The following is a description of a gene set: from publication Chen Y, Wang X (PMID 31504780) Mouse Gene Set: MIR_20A_5P studied in species Mus musculus Genes predicted to be targets of miRBase v22 microRNA mmu_miR_20a_5p in miRDB v6.0 with MirTarget v4 prediction scores > 80 (high confidence targets)., and this is the list of marker genes: Derl2, Phip, Frs2, Sema4b, Klf11, Cnot6l, Ppp1r3e, Pcdha6 (protocadherin alpha 6), Rps6ka1, Rp2, Osm, Tmem64, Kmt2a, Bicd2, Sobp, Tppp, Wasf1, Pcdha3, Npas2 (NCBI Gene Id 18143), Col19a1, Foxj2, Adam9, Midn, Tasor, Pkd2, Retreg3, Sertad2, C2cd2, Rab8b, Ccdc71l, B3galt2, Tspan9, Septin2, Rhoc, Dock4, Mmp24, Elk3, Lypd6, Map3k8, Map7, Myt1l, Limk1, Nek9, Csnk1g1, Panx2, Fbxo31, Arhgap12, Rab5b, Rab30, Rgmb, Gpc6, Rab3gap1, Rassf2, Pdcd1lg2, Topors, Rapgefl1, Ankrd33b, Nckap5, Kdm2a, Ppp1r3b, Pcdha5, Crybg3, Irf2bp2, Tanc2, Col4a4, Cbln4, Ythdf3, Irf9, Rb1, Plekha7, Trappc14, Pcdhac1, Tle4, Itgb8, Plxdc2, Rnf128, Pcdha8, Ntng1 (NCBI Gene Id 99752), Dnal1, Celsr2 (cadherin, EGF LAG seven-pass G-type receptor 2), Ano3, Fat4, Fyco1, Hs3st5, Il25, Reps2, Mosmo, Map6d1, Epha4, Zbtb18, Pak5, Marchf8, Slc17a8, Gramd1a, Ankrd17, Susd6, Acer2, Cald1, Snx8, Tph1, Rundc1, Zfpm2, Klhl28, Nr2c2, Prrg1, Aak1, Unk, Ube2q2, Egln3, Snx16, Aktip, Ss18l1, Slc24a2, Btbd10, P2rx4, Gbf1, Rcan3, Map3k14, Rgs17, Rap2c, Kif23, Map3k12, Slc25a36, Creb5, Rnf6, Klf9, Slc2a4, Osr1 (odd-skipped related transcription factor 1), Usp24, Tfb2m, Ppp1r21, Psd, Hbp1, Agfg2, Tsg101, Tmcc3, Enpp5, Slc49a4, Igsf10, Itpripl2, Spopl, Foxj3, Rsbn1, Usp3, Fzd3, Oxr1, Usp46, Cnot7, Arhgef10, Sema7a, Abca1, M6pr, Zdhhc1, Camta1, Eif4a2, Fam13c, Slc40a1, Gosr1, Coro2b, Lrp8, Znfx1, Stk38, Kpna2, Trip11, Pxk, Tmem127, Fam117b, Jpt1, Ptpn4, Tgfbr2, Slc16a9, Atxn7l1, Rab22a, Fibin, 1600012H06Rik, Smim5, Skor1 (SKI family transcriptional corepressor 1), Zfyve26, Sybu, Npat, Pcdha2, Nrip3, Arhgap26, Pafah1b1, Ints14, Trip10 (NCBI Gene Id 106628), Cdc37l1 (NCBI Gene Id 67072), Ankrd52, Arhgap1, Cfl2, Map3k2, Kif3b, Nabp1, Pcdha10, Luzp1, Mylip, Fcho2, Fastk, Tiam1, Ago1, Ddhd2, Fjx1, Stk11, Zbtb41, Dcaf8, Retreg2, Smyd1, Ddhd1 (DDHD domain containing 1), Kat2b, Zfp512b, Jazf1, Reep3, Nagk, Arhgef11, Creb1, Kif5a, 2510009E07Rik, Flt1, Cmpk1, Tnks2, U2surp, Hook3, Mknk2, Rab11fip5, Sqstm1, Gpr137b, Polr3g, Ncoa3, Zdhhc8, Ankrd13c, Atg16l1, Sumf1, Myf5, Brms1l, S1pr1, Tnfrsf21, Golga1, Neurog2, Armc8, Ptchd4, Cdca7, Wdr37, Smoc2, Ankrd9, Timp2, Mier1, Pbx3, Zfp800, Lrch1, Slc18a2, Pcdha9, Rgma, Naa30, Bnip2, Bahd1, Tbc1d9, Sfmbt1, Dpysl2, Laptm4a (lysosomal-associated protein transmembrane 4A), Ulk1, Pde3b, Slc6a9, Rps6ka5, Arhgef18, Pkd1, Rs1, Camk2n2, Dsg4, Atl3, Suco, Zfp91, Slc12a7, Crot, Gpr63, Gabbr2, Bbx, Nbea (NCBI Gene Id 26422), Tbc1d12, Lrrc55, Csrnp3, Scn1a, Smoc1, St3gal1, Dmtf1, Zfp704 (zinc finger protein 704), Ptpn21, Ezh1, Lama3, Sar1b, Txnip, Spred1, Rufy2, Zfp148, Tars2, Heg1, Lhx6, Bnc2, Sall1, Lratd2, E2f1, Cep120, Slc31a2, Gnb5, Eri1, Fndc3b, St6galnac3, Prr15, Slc22a23, St8sia2, Rps6ka4, Sorl1, Strip2, Zfp827, Mkrn1, Cast, Has2, Tbc1d8b, Rest, Tbcel, Frmd6, Idua, Npas3, Rnf2, Pcdha4, Pgm2l1, Iqsec2, Nfat5, Plekha3, Mink1, Pdgfra, Usp32, Dennd10, Fsd1l, Slc16a6 (NCBI Gene Id 104681), Fbxl5, Pkn2 (protein kinase N2), 6430548M08Rik, Tafa1, Cep97, Unkl, Akt3, Pex5l, Ndel1 (NCBI Gene Id 83431), Btg3, Pcdha12 (protocadherin alpha 12), Kcnk10, Neurog3, Pcdha11, Ccng2, Pfkp, Bcl2l11, Trim36, Cd69, Ube3c (ubiquitin protein ligase E3C), Zc3h12c, Purb, Fat2, Acsl4, Ldlrap1, Unc80, Uri1, Rasl11b, Xrn1, Crk, Dab2, Stx6, Rb1cc1, Srpk2, Mfap3l, Gon4l (gon-4 like), Uevld, Sh3pxd2a, Pthlh, Mtmr3, Clock, Abhd5, Slc25a40, Epha7, Trpv6, Wdfy3, Mapk4, Smad5, Sall3, Ugdh, Ogfod2, Gad2, Pkd2l2, Ahrr, Pcsk5, Rbbp7, Tnks1bp1, Mex3d, Mastl, Olfm1, Zbtb9 (zinc finger and BTB domain containing 9), Med12l, Dnajc24, Fnbp1l, Socs6, Dcbld2, Gid4, Vangl1, Dgkq, Rasd1, Gpr137c, Hlf, Nanos1, Prepl, Mapre3, Akap13, Zfp661, Wfs1, Nup35, Bcl11b, App, Gxylt1, Apcdd1, Kcnq2, Rock2, Zfp9, Dpysl5, Rab12, Rasgrf2, Fbxo21, Atxn1l, Slain2, Pitpna, Bmpr2, Dennd5b, Arid4b, Pgbd5 (piggyBac transposable element derived 5), Tmed8 (transmembrane p24 trafficking protein 8), Stxbp5, Kmt2b, Rsrp1, Kcnb1, Ankib1, Chmp4c, Rab10, Camta2, Ppp1r15b, Zfp236, Pcdha1, Ptpn3 (NCBI Gene Id 545622), Fgd5, Ahnak, Abcg4, Prr14l, Zfp367, St6galnac6, Dusp2, Trappc2, Tet1, Srcin1, Ssh2, Ficd, Lpgat1, E2f5, Atad2, Mfn2, Rab33b, Fam219b, Sos1, Fgd4, Tmem267, Clip4, Cc2d1a, F3, Sash1, Ism2, Ormdl3, Rbl2, Tnfaip1 (NCBI Gene Id 21927), Arhgap35, Vldlr, Zbtb4, Map3k13, Afg1l, Srgap1, Gab1, Fbxo28, Nedd4l (NCBI Gene Id 83814), Tmem123, Vash2, Slc17a7, Rnf150, Mospd2, Col4a3, Ano5, Hycc2, Pcdhac2, Zfand4, Cep57, Chd9, Ginm1, Chrm2 (cholinergic receptor, muscarinic 2, cardiac), Pls1, Glis3, Nr4a3, Mier2, Mapre1, Pnpla1, Zhx2, Pcdha7, Trim3, Sh3bp2, Atg14, Lima1, Napepld, Mcl1